The following is a description of a gene set: Any process that modulates the frequency, rate or extent of excitatory postsynaptic potential (EPSP). EPSP is a process that leads to a temporary increase in postsynaptic potential due to the flow of positively charged ions into the postsynaptic cell. The flow of ions that causes an EPSP is an excitatory postsynaptic current (EPSC) and makes it easier for the neuron to fire an action potential. Mouse Gene Set: GOBP_MODULATION_OF_EXCITATORY_POSTSYNAPTIC_POTENTIAL studied in species Mus musculus, and this is the list of marker genes: Prkn, Shank1, Mtmr2, S1pr2, Ssh1, Dbn1, Rgs4, Plk2, Igsf11, Adrb2, Nlgn1, Npy2r, Prkar1b, Drd4, Pclo, Grik1, App, Eif4a3l1, Grin2d, Grip2, Cbln1, Rims2, Chrna7, Grk2, Eif4a3l2, Grin2b, Pten, Nlgn4l, Ngfr, Stx1a, Nrxn1, Dmpk, Tmem108, Reln, Neto2, Slc8a3, Celf4, Shank3, Grik2, Cacnb3, Nlgn3, Tmem25, Rims1, Eif4a3, Zmynd8, Cux2, Grin2c, Grin1, Stx1b, Prkcz, Ptk2b, Lrrk2, Sh3gl1, Dvl1, Dlg4, Gria1, Afdn (NCBI Gene Id 240024), Baiap2, Neto1, Slc8a2, Grin2a, Tbc1d24, Gsk3b, Wnt7a, Nlgn2